The following is a description of a gene set: species: Mus musculus Mouse Gene Set: GOBP_EXECUTION_PHASE_OF_APOPTOSIS A stage of the apoptotic process that starts with the controlled breakdown of the cell through the action of effector caspases or other effector molecules (e.g. cathepsins, calpains etc.). Key steps of the execution phase are rounding-up of the cell, retraction of pseudopodes, reduction of cellular volume (pyknosis), chromatin condensation, nuclear fragmentation (karyorrhexis), plasma membrane blebbing and fragmentation of the cell into apoptotic bodies. When the execution phase is completed, the cell has died., and this is the list of marker genes: Mtrnr2l7, Ern2, Col6a1, Fadd, Dlc1, Plscr2, Casp3, Taok1, Madd, Acin1, Nmnat1, Fasl, Nfkbiz, Cidea, Dicer1, Dnase2a, Xkr9, Xkr6, Hsf1, Cideb (NCBI Gene Id 68665), Il6, Dffa, Trpc5, Xkr4, Gata5, Xrcc4, Endog, Plscr1, Xkr8, Tnfrsf1a, Aifm3, Bok, Bax, Zc3h12a, Rbm10, Top2a, Blvra, Dedd2, Fap, Ano6, Cdk5rap3, Casp7, Kdm4a, Cxcr3, Cd24a, Ptgis, Gcg, Igfbp3, Ripk1, Bcl2l1, Acvr1c, Vps54, Htr2a, Stk24, Trp53, Ctsd, Fzd3, Cdkn2a, Akt1, Exog, Cidec, Trp53bp2, Sirt2, Dffb, Aifm1, Dnase2b, Hspd1 (heat shock protein 1 (chaperonin)), Apaf1 (apoptotic peptidase activating factor 1), Htra2, Foxl2, Bbc3, Npr2, Bcl10, Dnase1l3, Casp8, Blcap, Gper1, Hnf1a, Tradd, Cecr2, Sharpin (NCBI Gene Id 66081), Xkr7, Ndufa13